The following is a description of a gene set: species: Homo sapiens Human Gene Set: BUSSLINGER_GASTRIC_X_CELLS from publication Busslinger GA, Weusten BLA, Bogte A, Begthel H, Brosens LAA, Clevers H (PMID 33691112), and this is the list of marker genes: PCSK1N, GHRL, LY6H, FAM210B, CITED4, HLA-C, CCNI, GRIA2, PROX1 (prospero homeobox 1), C12orf75, SERPINA1, SPATS2L, JUNB, SNAP25 (synaptosome associated protein 25), FOS, IDS, CRY2, PBXIP1, FBXL16, PNRC1, BTG2, SYT4, IL20RA, KIF1A, DSP, SSR4, DDX24, TUBA1A, PDE2A, CHGB, NSG2, CAMK2B, PDE8B, CALM1, DST, AKAP9, H3-3B, PBX1, PCBP4, CNGA3, ACSL1, ISYNA1 (inositol-3-phosphate synthase 1), TMEM176A, MAP1B, CLU, MLXIPL, CALD1, MDK, SERPINB6, BEX3, SLC22A17, PTOV1, RHOBTB3, CEP126, INA, QDPR, USH1C, ZKSCAN1, ATN1, PCSK1, TNRC6A, CFC1, RASA4, MT1F, CALY, RAB26, IGFBP5, STMN2 (stathmin 2), SRRM4, NNMT, FLNB, SEZ6L2, SCG3, RFX6, RIMBP2, BAIAP3, PHIP, ENPP1, A1CF, SYT7, NIPSNAP1, S100A1, AP1AR, ASAH1, ADARB1, KIF13B, MAP2, NEUROD1, TTR, VAMP2, KAT6B, CIRBP, NEURL1, BAZ2B, BACE1, APPL2, HOOK3, IRX2, ARFGAP3, PTPRN, VTN, GC, PFN2, ARX, GCC2, GUSBP14, SMARCA2 (SWI/SNF related, matrix associated, actin dependent regulator of chromatin, subfamily a, member 2), SCGN, PCLO, RTN4, CMTM8, SORBS2, DDX5, GNAI2, CXXC4, WSB1, CHD7, NR2F2, NAV1, PPP1R1A, LRATD1, MSLN (mesothelin), GPR160, MAOB, KCNH2, ANXA7, GK5, TMEM176B, HPN, APOA1, TEAD1, LPP, PSAP, KCTD12, MAFB, DEPP1, RBP1, MS4A8, REV3L, HEPACAM2, UCP2, PAPSS2, EGR1, ARRDC4, GPX3, MMRN1, JUND, IER2, BEX1, VSTM2L, IRF2BP2, FGF14, JUN, CPE, CACNA1A, SOX6, TP53I13, CPLX2, GNAO1, KCNMA1, PBX3, WNK3, NKX2-2, ASS1, NISCH, BHMT (NCBI Gene Id 83323), DUSP1, KCNJ3, KIF5C, RIMS2, ST18, PRKAR1A, OLFML3, ABCC8, IGDCC3, ATF3, VPS13C, ARFGEF3, TM4SF4, FAR2P2, LRRFIP1, EIF4G2, VWA5B2, LINC00261, FAR2P1, APBB1, PKM, ALDH1A1, SPRN, CBX6, RAPGEF4